The following is a description of a gene set: species: Homo sapiens Genes predicted to be targets of miRBase v22 microRNA hsa-miR-8083 in miRDB v6.0 with MirTarget v4 prediction scores > 80 (high confidence targets). from publication Chen Y, Wang X (PMID 31504780) Human Gene Set: MIR8083, and this is the list of marker genes: DCLK1, HCN1, EIF3CL, BCL11B, DPP8, HSPA9, SCUBE2, VCAN, AZI2, ITPRID2, TOX, LRP4, CASK, TMPPE, SFTPB, DTWD1, STRN3, PDE6H (phosphodiesterase 6H), INTS5, ZBTB41, ZMYND11, AFTPH, GABRP, C1QL3, EIF3C, KLF7, TXNIP, HAL, MAML1, PRIM2, KIF13A, SSH1, ZFP3, BTBD7, TTC8, KHDRBS1, TULP3, ALDH1A3, ATP8B1, GSG1, SP7, ZHX2, GIPC2, SLC44A1, DEFA6, PTPRD, CLDN18 (claudin 18), PSAT1, NRP2, APBB2, DCP1B, SLC22A5, SYNCRIP, PLCH1